The following is a description of a gene set: Any process that results in a change in state or activity of a cell (in terms of movement, secretion, enzyme production, gene expression, etc.) as a result of a cocaine stimulus. Cocaine is a crystalline alkaloid obtained from the leaves of the coca plant. studied in species Mus musculus Mouse Gene Set: GOBP_CELLULAR_RESPONSE_TO_COCAINE, and this is the list of marker genes: Comt, Slc1a1, Tgm2, Ppp1r1b, Crhbp, Slc1a2, Crh, Ccna2, Slc1a3, Ehmt2